The following is a description of a gene set: Molecular pathway for oxidative stress species: Homo sapiens Human Gene Set: WP_MOLECULAR_PATHWAY_FOR_OXIDATIVE_STRESS, and this is the list of marker genes: RHEB, NOX1, MAPK8, NFE2L2, MTOR, IPCEF1, NFKB1, PTGS2, CCNE1, IKBKB, NRF1, AKT1, CREB1, PINK1, BCL2, SIRT1, MAPK14, TP53, PIP, TNF, CDK2, CDKN1A, MAP3K5, PIK3CA, ATF2, FOS, IL1A, CXCL8, CAT, BCL2L1, MAP2K3, IL6, CHEK1, RPS6KA5, KEAP1, NOS2, NQO1, MAP2K4, TSC1, GSX1, PTEN, ATR, CUL3, MDM2, ICAM1, IKBKG, FOXO1, HMOX1